The following is a description of a gene set: Mouse Gene Set: GOMF_SEROTONIN_RECEPTOR_ACTIVITY Combining with the biogenic amine serotonin and transmitting a signal across a membrane by activating some effector activity. Serotonin (5-hydroxytryptamine) is a neurotransmitter and hormone found in vertebrates and invertebrates. species: Mus musculus, and this is the list of marker genes: Htr2b, Htr2c, Htr4, Htr1a, Htr2a, Htr6, Htr1b, Chrna10, Htr5a, Htr1f, Htr3b, Htr3a, Chrna9